The following is a description of a gene set: studied in species Mus musculus Mouse Gene Set: REACTOME_REGULATION_OF_PTEN_LOCALIZATION Regulation of PTEN localization, and this is the list of marker genes: Usp7, Uba52rt, Nedd4, Ubc, Uba52, Pml, Rps27a (NCBI Gene Id 78294), Xiap, Ubb, Pten